The following is a description of a gene set: Human Gene Set: MIR4695_3P species: Homo sapiens from publication Chen Y, Wang X (PMID 31504780) Genes predicted to be targets of miRBase v22 microRNA hsa-miR-4695-3p in miRDB v6.0 with MirTarget v4 prediction scores > 80 (high confidence targets)., and this is the list of marker genes: PWWP3B, CUL3, MRI1, FARP1, ZNF420, INTS7, RIDA, PDLIM3, EIF4E3, GTF2H5, PSD2, LRIT2, SNX2 (NCBI Gene Id 6643), LBH, SLC38A1, LMAN1, PROP1 (NCBI Gene Id 5626), KPNA4, DCAKD, LGR5, SV2C, ZNF10, ZBED10P, SLC35D1, SDC2, ELK4, ZNF250, DDX3X, SLC17A3, OTX2, GMFB, TRDMT1, ODAPH, TCEA1, CALB1, SOX3, DPYS, MXD3, MCTP2 (multiple C2 and transmembrane domain containing 2), FAM107B, BAZ1A, GPR75, C5AR1, KLF7, ADRA2A, IFT88, LCOR, ARFGEF3, NBEA, ENAH, ABLIM3, LRRC66, E2F6, PURG (NCBI Gene Id 29942), REST, SPRED1, WDR26, SLC17A7, PTGFR, CHRNA7, SLC7A14, EDA2R (ectodysplasin A2 receptor), ROPN1, ATXN7, CFAP61, TANC2, ARRDC4, KIF16B, MAP3K7CL, ISL1, PARS2, CFL2, PIGK, FGD6, LAMP2, DLEC1, ZNF394, CEP112